Given this list of marker genes COQ4 (coenzyme Q4), PPP3CC, ZC3H12A, CKS1B, NDUFA8, NSUN3, PAPSS2, HSPA2, PALLD, AQP9, MRPL17, SERPINE2, TRADD, GLA, JAM2, RORB, UNC119, LY6E, CLUAP1, TMEM255A, HRH3 (histamine receptor H3), SLC2A3, KCNK15-AS1, GPR27, PCNX1, SCG5, KCNC1, SIGLEC1, SUPT3H, SLC25A37, ARL15, NLRP3, PMAIP1, MYO5C, ECE1, PRDX4, C1GALT1, ARL8B, SAV1, ALPK3, FPR1, RAB13, IFI44L, MYBPC2, TRAF6, SFT2D2, TAP2, AIDA, EDN1, USP15, SP140L, NOL3, HAS2, SNX10, RAG2, TGFA, MT1E, MREG, CKS2, CLSPN, GNA14, TMEM187, RBM28, ABCC2, IL2RA, CD226, LTA, PCSK1N, BAK1, LBP, SERPINB2, MAP2, TWNK, LYVE1, WTAP, SOS1, SEZ6L, OPTN (optineurin), PLAT, ATOX1, TNFAIP8, GNAT3, PTX3, TCL1B (TCL1 family AKT coactivator B), RALGAPA1, RCL1, SERPINB7, MTERF1, AHR, RABGEF1, MSL3, NADK, RUNDC3B, TBK1, IFI35, NDP, LEFTY1, RHOQ, VASH2, CD40, TULP1, SLC37A1, FCER2, LAMP3, CLIP3, CABYR, CASP7, TTLL4, IRS1, ARHGAP29, GIMAP6, RGN, IRF1, PLEKHA6, JAK2, KBTBD2, MST1R, SORT1, ATF3, LRRFIP2, OLFM1, CALM1, ZNF750 (zinc finger protein 750), BTG3, BHLHE40, ALAS1, CYP2J2, DHX58, PSMA6, DGLUCY, CACNA1D, GGT1, DDX10, IFNG, C3, CD48, MGLL, MYO1B, SOX5, CHST2, CASP5, KIF25, IRAK3, MTF1, LDHA, MAB21L1, TOR1B, WNT5A, PLAUR, HCP5, LAGE3, ZBTB43, SVIL, CDK17, H2BC21, SLC7A7, ADM, RFX5, CHMP5 (charged multivesicular body protein 5), MCL1, H3-3B, YRDC, CABP2, SHFL, HRH1, PKIG (NCBI Gene Id 11142), HSD11B1, CCL8, HBEGF, HK2, ARR3, OGFRL1, NFKBIE, OR2B2, ATF6B, KCNK10, GIMAP4, MSC, DENND5A, APOD, TRANK1, EXOC2, MAD2L1BP, REG1B, ZMIZ2, IPCEF1, IFIT5, GADD45B, CD59, TRAFD1, FKBP5, DZIP1, ASAP1, IL1RN, BANP, KIAA0040, RUVBL1, ITGB3, here is a description of the gene set: The immune responses generated by YF-17D by profiling genes in PBMCs from 2 donors cultured with YF-17D vaccine were accessed after 3 and 12 hours. from publication Querec TD, Akondy RS, Lee EK, Cao W, Nakaya HI, Teuwen D, Pirani A, Gernert K, Deng J, Marzolf B, Kennedy K, Wu H, Bennouna S, Oluoch H, Miller J, Vencio RZ, Mulligan M, Aderem A, Ahmed R, Pulendran B (PMID 19029902) Human Gene Set: GSE13484_12H_UNSTIM_VS_YF17D_VACCINE_STIM_PBMC_DN Genes down-regulated in comparison of unstimulated peripheral blood mononuclear cells (PBMC) cultured for 12 h versus PBMC cultured for 12 h with YF17D vaccine. species: Homo sapiens